The following is a description of a gene set: An abnormal configuration of the lower lip such that it is turned outward i.e., everted, with the Inner aspect of the lower lip vermilion (normally opposing the teeth) being visible in a frontal view. Human Gene Set: HP_EVERTED_LOWER_LIP_VERMILION studied in species Homo sapiens Everted lower lip vermilion, and this is the list of marker genes: MED12L, CDKL5, FGD1 (NCBI Gene Id 2245), BDNF, ERCC1, MECP2, TFAP2A, IFT52, MDH1, SALL4, ALOXE3, TMEM270, NCF1, PLXND1, TFAP2B, BAZ1B, H3-3A (NCBI Gene Id 3020), FHL1, RBMX, ERCC6, POGZ, SULT2B1, PIGL, UBAP2L, EEF1A2, KANSL1, TBC1D24, DENND5A, METTL27, POMGNT1, BCAS3, MCOLN1, AHDC1, TAF4, EDNRA, ADAMTS2, STX1A, ATRX (ATRX chromatin remodeler), BUD23, ESAM, MSX1, LIPN, RFC2, GTF2IRD2, ELN, TNPO2 (transportin 2), BCL11A, RNU4-2, FKBP6, GTF2IRD1, KIFBP, WT1, KCNH1, SDR9C7, WDR35, TMEM147, PACS2, HSPG2, SNRPN, TGM1, ABCA12, IGF1R, ACBD6, ASXL3, NFIX, TBL2, SPECC1L, TBL1XR1, TFE3, SMS, ZSWIM6, RPS6KA3, HRAS, PAX6, IDUA, FOXG1, CHAMP1, CLIC2, IRX5, DRG1, SRCAP, DNAJC30, SLC25A24, IFT56 (NCBI Gene Id 79989), SMG9, MBD5, ASPRV1, REV3L, GBA1, PCDHGC4, KCNMA1, OBSL1, FRMD4A, HGSNAT, KMT2C, CHN1, MYO18B, EHMT1, MGAT2, SOX11, RPL10, IFT122, RAB3GAP2, SCARF2, MED13L, EIF4H, EDA2R, MYCN, ADNP, CUL7, PITX2, QRICH1, FOXC1, MAFB, ABHD5, DOCK7, NIPAL4, WDR19, FBXL4, ERCC5, LIMK1, SMARCA2, BMP2, EDARADD, GTF2I, EDAR, OCRL, IFT43, RAB3GAP1, EDA, VPS37D, CDH11, CYP4F22, NRAS, DHX30, MED25, CCDC8, CLIP2, ANTXR1, ALOX12B, ERCC2, PUS7, FBXO11